Given this list of marker genes Psma4, Cdc26 (NCBI Gene Id 66440), Ube2c, Psmc2, Psmb7, Anapc15, Anapc7, Psma6, Psmd6, Ube2d1, Psmb5, Psma3, Psmc5, Fzr1, Psmb6, Psma1, Ube2s, Psmc1, Ube2e1 (ubiquitin-conjugating enzyme E2E 1), Psmc4, Psmb4, Psmc3, Psma5 (NCBI Gene Id 26442), Cdc23, Psmd7, Psmd12, Psmd13, Psma2, Anapc2, Rps27a, Psmd1, Ubb, Psmc6, Psma7, Anapc10, here is a description of the gene set: part of: APC/C-mediated degradation of cell cycle proteins species: Mus musculus This event has been computationally inferred from an event that has been demonstrated in another species.<p>The inference is based on the homology mapping from PANTHER. Briefly, reactions for which all involved PhysicalEntities (in input, output and catalyst) have a mapped orthologue/paralogue (for complexes at least 75% of components must have a mapping) are inferred to the other species. electronically inferred by orthology from the curated human pathway Reactome Pathway: Autodegradation of Cdh1 by Cdh1:APC/C